The following is a description of a gene set: Catalysis of the reaction: a long-chain fatty acid + ATP + CoA = a long-chain fatty acyl-CoA + AMP + diphosphate. A long-chain fatty acid has an aliphatic tail containing 13 to 22 carbons. species: Mus musculus Mouse Gene Set: GOMF_LONG_CHAIN_FATTY_ACID_COA_LIGASE_ACTIVITY, and this is the list of marker genes: Acsm1, Slc27a6, Acsl4, Acsbg3, Acsl6, Slc27a5, Acsl1, Acsl5, Acsbg1, Acsl3, Slc27a2, Slc27a4, Slc27a3, Acsbg2, Slc27a1